Given this list of marker genes Htr5b, Gnai1, Htr4, Htr1f, Htr1a, Htr1d, Htr1b, Htr5a, Gnao1, here is a description of the gene set: An adenylate cyclase-inhibiting G protein-coupled receptor signaling pathway initiated by serotonin binding to its receptor, and ending with the regulation of a downstream cellular process. Mouse Gene Set: GOBP_ADENYLATE_CYCLASE_INHIBITING_SEROTONIN_RECEPTOR_SIGNALING_PATHWAY species: Mus musculus